Given this list of marker genes TEAD2, TAF10, NODAL, FOXH1, FOXF1, NOMO1, YAP1, MESP1, SMO, NCLN, CITED2, NOMO3, DAND5, SMAD2, TBX20, BMPR1A, SHH, FGFR1, here is a description of the gene set: The process whose specific outcome is the progression of the lateral mesoderm over time, from its formation to the mature structure. Human Gene Set: GOBP_LATERAL_MESODERM_DEVELOPMENT species: Homo sapiens